Given this list of marker genes APC, FGFR2, KLF6, KRT18, ERBB2, IL1B, IL1RN, MUTYH, CASP10, SMAD4, KRAS, ACVR1B, IRF1, STK11, TP53, PIK3CA, here is a description of the gene set: Human Gene Set: HP_INCREASED_LEVEL_OF_L_FUCOSE_IN_URINE Increased level of L-fucose in urine An increase in the level of L-fucose in the urine. species: Homo sapiens